The following is a description of a gene set: species: Mus musculus Any process that modulates the frequency, rate or extent of membrane hyperpolarization. Mouse Gene Set: GOBP_REGULATION_OF_MEMBRANE_HYPERPOLARIZATION, and this is the list of marker genes: Rbfox2, Crtc1, Hcn1 (hyperpolarization activated cyclic nucleotide gated potassium channel 1), Agt, Cacnb3, Trpc5, Sod2